Given this list of marker genes MOV10, E2F1, MAPK1, TP53, MDM2, TNRC6C, E2F3, MIR24-2, UBB, TFDP1, CDKN2C (cyclin dependent kinase inhibitor 2C), TFDP2, ETS2, MAPK3, ERF, CDKN2B, AGO4, CDKN2A, AGO3, CDK4, ID1, ETS1, UBA52, AGO1, CDK6, E2F2, TNRC6B, UBC, MDM4 (NCBI Gene Id 4194), SP1, RB1, CDKN2D, RPS27A, MIR24-1, TNRC6A, here is a description of the gene set: species: Homo sapiens Human Gene Set: REACTOME_ONCOGENE_INDUCED_SENESCENCE Oncogene Induced Senescence